Given this list of marker genes RPS3A, NAP1L1, UBC, MMP24OS, KLF5, CYP1A1, ST6GALNAC4, PTP4A2, ANP32A, LRP5, GAPDH, EPHB4, TPT1, RPS11, PGK1, SEL1L3, PTK2, RPS6, B2M, RPLP0, FAM120A, EEF1A1, EIF5A, RPL23, CA12, UGT1A10, UGT1A8, LRRFIP1, KDELR1, HSPA8, here is a description of the gene set: studied in species Homo sapiens from publication Tien MT, Girardin SE, Regnault B, Le Bourhis L, Dillies MA, Coppée JY, Bourdet-Sicard R, Sansonetti PJ, Pédron T (PMID 16394013) Shigella invades the human intestinal mucosa, thus causing bacillary dysentery, an acute recto-colitis responsible for lethal complications, mostly in infants and toddlers. Conversely, commensal bacteria live in a mutualistic relationship with the intestinal mucosa that is characterized by homeostatic control of innate responses, thereby contributing to tolerance to the flora. Cross-talk established between commensals and the intestinal epithelium mediate this active process, the mechanisms of which remain largely uncharacterized. Probiotics such as Lactobacillus casei belong to a subclass of these commensals that modulate mucosal innate responses and possibly display anti-inflammatory properties. We analyzed whether L. casei could attenuate the pro-inflammatory signaling induced by Shigella flexneri after invasion of the epithelial lining. Cultured epithelial cells were infected with L. casei, followed by a challenge with S. flexneri. Using macroarray DNA chips, we observed that L. casei down-regulated the transcription of a number of genes encoding pro-inflammatory effectors such as cytokines and chemokines and adherence molecules induced by invasive S. flexneri. This resulted in an anti-inflammatory effect that appeared mediated by the inhibition of the NF-kappaB pathway, particularly through stabilization of I-kappaBalpha. In a time-course experiment using GeneChip hybridization analysis, the expression of many genes involved in ubiquitination and proteasome processes were modulated during L. casei treatment. Thus, L. casei has developed a sophisticated means to maintain intestinal homeostasis through a process that involves manipulation of the ubiquitin/proteasome pathway upstream of I-kappaBalpha. Genes up-regulated in Caco-2 cells (intestinal epithelium) after coculture with the probiotic bacteria L. casei for 2h. Human Gene Set: TIEN_INTESTINE_PROBIOTICS_2HR_UP